The following is a description of a gene set: Abnormal circulating glutamine family amino acid concentration species: Homo sapiens Any deviation from the normal concentration of a glutamine family amino acid in the blood circulation. Human Gene Set: HP_ABNORMAL_CIRCULATING_GLUTAMINE_FAMILY_AMINO_ACID_CONCENTRATION, and this is the list of marker genes: ALDH4A1, ASL, PNPO, PRODH (NCBI Gene Id 9539), SLC7A7, CPS1, ATP5F1A, COX10, TARS2, SLC6A19, SLC36A2, LIPT1, COX16, NAGS, PDP1, SLC6A18 (solute carrier family 6 member 18), ARG1, COX5A, TNFRSF11B, NDUFC2, SLC25A13, TALDO1, GLUL, ALDH18A1, ASS1, TEFM, OTC, SLC6A20, MDH1, CA5A, GLS, NDUFB10